The following is a description of a gene set: Human Gene Set: HP_ERECTILE_DYSFUNCTION Erectile dysfunction A multidimensional but common male sexual dysfunction that involves an alteration in any of the components of the erectile response, including organic, relational and psychological. studied in species Homo sapiens, and this is the list of marker genes: SACS, IL17RD, ENSG00000288330 (NCBI Gene Id 724066), SPRY4, LMNB1, NDP, FMR1, IRF4, CDH23, WDR11, MEN1, ABCD1, BMP6 (NCBI Gene Id 7964), AR, NF2, TRAF7, HFE, NSMF, BMP2, DCC, NDNF, CHD7, PROK2, GALC, FGFR1, TACR3, SUFU, CACNA1G, FGF8, PIK3CA, PDGFB, HAMP, TERT, PROKR2, DUSP6, TAC3, PIGA, HEXB, HBB (NCBI Gene Id 3043), CDKN2B (cyclin dependent kinase inhibitor 2B), CDKN2C, SOX10, SMARCE1, GNRHR, AKT1, HS6ST1, CDKN1B, TTR, GUCY1A1, ANOS1, SMO, AIP (NCBI Gene Id 9049), SLC40A1, NR0B1, CCDC141, COQ2, GPR101, KISS1, ATXN8OS, CDKN1A, HESX1, FGF17, NHLH2, KISS1R, BAP1, FEZF1, HJV, GNRH1, SMARCB1, SEMA3A (NCBI Gene Id 63232), TFR2, FLRT3